Given this list of marker genes CACNA1S, GAA, TRPM4, KCNJ18, MTFMT, MT-CYB, PRKAG2, DOHH, GABRA3, here is a description of the gene set: species: Homo sapiens Human Gene Set: HP_SHORTENED_PR_INTERVAL Shortened PR interval Reduced time for the PR interval (beginning of the P wave to the beginning of the QRS complex). In adults, normal values are 120 to 200 ms long.